Given this list of marker genes ANKS1B, NFIX, GRB10, SPATA33, DLGAP3, CYP4F22, SCRT1, TRIM48, SLC29A3, FGD5, SOBP, ZNF385A, PRR36 (NCBI Gene Id 80164), ATP1A3, PAX2, KLK9, AAK1, VSTM2L (V-set and transmembrane domain containing 2 like), DPF1, here is a description of the gene set: Genes predicted to be targets of miRBase v22 microRNA hsa-miR-6816-5p in miRDB v6.0 with MirTarget v4 prediction scores > 80 (high confidence targets). from publication Chen Y, Wang X (PMID 31504780) Human Gene Set: MIR6816_5P species: Homo sapiens